Given this list of marker genes TUBA1A, WNT7A, AARS1, SERPINE2, KIF14, KNDC1, PROX1, TRNP1, UQCRQ, KLHL1, SMO, SKOR2, GRID2, GLI1, RERE, LHX5, DLL1, MDK, HSPA5 (heat shock protein family A (Hsp70) member 5), SEZ6, ZNF365, GBA1, HERC1, CEND1, TTBK2, B4GALT2, NRXN1, MAP2K1, FOXP2, LDB1, WHRN, COMT, EZH2, GLI2, NEUROD2, SLC25A46, MYH10, NAGLU, ATP7A (NCBI Gene Id 613259), NAV2, SPTBN2, TTLL1 (NCBI Gene Id 25809), CDK5, RORA, FKTN, ARCN1, OGDH, OPHN1, AGTPBP1, PTPN11, CBLN1, TTC21B, FAIM2, LHX1, COQ8B, CLP1, here is a description of the gene set: studied in species Homo sapiens Human Gene Set: GOBP_CEREBELLAR_CORTEX_DEVELOPMENT The process whose specific outcome is the progression of the cerebellar cortex over time, from its formation to the mature structure. The cerebellar cortex is a thin mantle of gray matter that covers the surface of each cerebral hemisphere. It has a characteristic morphology with convolutions (gyri) and crevices (sulci) that have specific functions. Six layers of nerve cells and the nerve pathways that connect them comprise the cerebellar cortex. Together, these regions are responsible for the processes of conscious thought, perception, emotion and memory as well as advanced motor function.